The following is a description of a gene set: Human Gene Set: GOBP_CELLULAR_RESPONSE_TO_HISTAMINE studied in species Homo sapiens Any process that results in a change in state or activity of a cell (in terms of movement, secretion, enzyme production, gene expression, etc.) as a result of a histamine stimulus. Histamine, the biogenic amine 2-(1H-imidazol-4-yl)ethanamine, is involved in local immune responses as well as regulating physiological function in the gut and acting as a neurotransmitter., and this is the list of marker genes: GABRG2, HRH1 (NCBI Gene Id 3269), DIAPH1, GABRB1, GABRB3, GABRB2